The following is a description of a gene set: Binds to and stops, prevents or reduces the activity of phospholipase A2. species: Mus musculus Mouse Gene Set: GOMF_PHOSPHOLIPASE_A2_INHIBITOR_ACTIVITY, and this is the list of marker genes: Anxa2, Anxa3, Ppt1, Anxa1, Scgb1a1